The following is a description of a gene set: from publication Chaussabel D, Semnani RT, McDowell MA, Sacks D, Sher A, Nutman TB (PMID 12663451) species: Homo sapiens Monocyte-derived dendritic cells (DC) and macrophages (MΦ) generated in vitro from the same individual blood donors were exposed to five different pathogens, and gene expression profiles were assessed by microarray analysis. Responses to Mycobacterium tuberculosis and to phylogenetically distinct protozoan (Leishmania major, L. donovani, Toxoplasma gondii) and helminth (Brugia malayi) parasites were examined, each of which produces chronic infections in humans yet vary considerably in the nature of the immune responses they trigger. Human Gene Set: GSE360_L_DONOVANI_VS_T_GONDII_DC_UP Genes up-regulated in comparison of dendritic cells (DC) exposed to L. donovani versus DCs exposed to T. gondii., and this is the list of marker genes: NDUFA6, DNAJA3, TMPRSS15, SEC14L2, KIF5A, KTN1, H1-1, PTK7, INPP5D, SMAP1, AQP4, ERLIN2, GJA5, PRDM2 (PR/SET domain 2), SLC30A1, GAS2L1, FOLR2, NR3C2, KCNG1, AMPD2, CACNA1S, ATRNL1, GBX1, INHA, TNFSF12, ALDH3B1, TMEM151B, CRHBP, PPP1R2C, GNAI3, HOXA2, TMEM262, EPN2, ACTN1, OVOL2, SYT11, STON1, SMAGP, FANCC, SFXN3, MMP9 (NCBI Gene Id 4318), NEDD4, EDN2, FIG4, ZNF804A, RUNDC3B, APOC3, NUDT3, RPL39L, PAX5, BAP1, MAGEA12, ADIPOQ, SPAM1, PLIN2, SPAG6, ITGA8, MYL12B, TBXAS1, DIS3, FABP6 (fatty acid binding protein 6), MYH6, NXPH3, SP4, NPTN, ODF2, FRAT2 (NCBI Gene Id 93368), FBXL2, HOXB13, KRT15, ABCD1, OCA2, TACR3, RPE, KLHL35, G6PC1, PLXNB2, MAFK, TTC9, LDB2, LEFTY2, SSX5, RAC2, PTGER2, PPY, GMFB, FLOT1, MYOG, LAMA4, DNAL4, ZNF391, YIPF1, IL18RAP, FBXL5, AOPEP, DNAH7, GPC1, RLN2, PRKCH, SMR3B, SPOCK1, SLC25A44, RNF13, PPIH, BAAT, HSPB6, CCR4, CACNA1E, SLC16A4, DGCR6L, SORBS2, HMX1, ZNF169, FCN1, HOXC4, TM4SF4, KMT2D, ADAM19, ADAM11, CYLC2, APOC2, KIFC3 (kinesin family member C3), ANXA2P1, FGG, GNAQ, RAD54L2, ELK1, ADAMTS2, ABCB8, SPTLC2, LRRC17, MMP24, GFER, MAG, LITAF, CRYBA4, CYP2C9, SMG6, PTGES (prostaglandin E synthase), ENO2, TG, NIPAL3, SPOCK3, UBL3, NR6A1, EIF3K, CCDC181, NCR2, OR5I1, SLC2A1, MYH8, MXRA5, RASAL2, FOXI1, KCNS3, CHRNA3, PLA2G7, EYA2, CRTAM, C8A, APOBEC2, ASIC1, ANKRD28, PEX11A, PDE9A, GM2A, PCDHGA12, SYT2, GMDS, PLG, ENTPD2, GNAL, C1S, CAPNS1, SRY, ACSBG1, PRM1, MBP, TBC1D12, IL2RB, VSNL1, PHKG2, AHNAK, MUC7, LIMCH1, P2RX6, CCND1, ADGRG2, ANXA9, GNA15, TLR5, NKX2-2, RNF6, PTPN12, LYSET, FOXN1, CTNNA2, STX3, KCNB1, CHRNA4